Given this list of marker genes Gm13889, Vegfb, Rgma, Nfat5 (nuclear factor of activated T cells 5), Pate9, Daam2, Slc41a1, Zfp652, Ntrk2, Cul5, Apmap, Msn, Rfx4, Tcf20, Sec1 (NCBI Gene Id 56546), Nrn1, Stxbp4, Cfap61, Golph3l, Plxna4 (plexin A4), Palm, Sorcs3, Tmem150c, Trarg1, Arfgef1, Il18r1, Tead1, Zxdb, Vcan, Zeb2, Ddx10, Gm14322, Tmem229a, Timd6, Ptprr, Nbea, Nol3, Vti1a, D630045J12Rik, Samd4b (NCBI Gene Id 233033), Il33, Epha3, Terf2ip, Dlk1, Ccdc127, Dpp10, Tacr1, Garem2, Srsf12, Iars1, Rit1, Bace2, Fyco1, Nkain1, Cat, Ndp, Atp1b1, Kcnt1, Prmt2, Taf6, Insig1, Gpr141b, Tmem229b, Car10, Fndc1, Mdga1, Idh1, Bpi, Iqsec2, Mmgt1, Adgrb2, Tectb, Nsd1, Kmt5a, Reep1, Nlrc3, Sp4, Cdh12, Onecut2, Srp72, Ythdc2, Tnfaip1, Kif18b, Sema7a, Ift70a1, Fam149b, Kif1b, Mfsd6, Mkrn1, Elfn1, Shank1, Nkg7, Dhdh, Thrb, Iars2, Ezh1, Rnasel, Rnf169, Rgs5, here is a description of the gene set: Genes predicted to be targets of miRBase v22 microRNA mmu_miR_574_5p in miRDB v6.0 with MirTarget v4 prediction scores > 80 (high confidence targets). from publication Chen Y, Wang X (PMID 31504780) species: Mus musculus Mouse Gene Set: MIR_574_5P